The following is a description of a gene set: species: Homo sapiens Human Gene Set: HP_OROFACIAL_DYSKINESIA Orofacial dyskinesia, and this is the list of marker genes: PANK2, MICU1, SLC35A1, PI4K2A, PLP1, PDE10A, GBA2 (NCBI Gene Id 57704), COQ2, AARS1, PRRT2, FTL, LRPPRC, SLC6A3, ADCY5, ATXN7, CYP27A1, FGF14, VPS13A, JAM2, IREB2, CACNA2D1, CHMP2B, GNAO1, MRE11, SLC18A2, PNPT1, EXOSC5, PRKRA